The following is a description of a gene set: studied in species Homo sapiens The chemical reactions and pathways resulting in the breakdown of compounds derived from amino acids, organic acids containing one or more amino substituents. Human Gene Set: GOBP_MODIFIED_AMINO_ACID_CATABOLIC_PROCESS, and this is the list of marker genes: AGXT2, PCYOX1L, HOGA1, ALDH1L1, GOT2, PRODH, GGT7, GGT3P, DMGDH, ABHD12B, ABHD16B, DIO1, BHMT, GGTLC1, AASDHPPT, ABHD12, PCYOX1, DIO3 (NCBI Gene Id 1735), PM20D2, SARDH, ABHD16A, CHAC1 (NCBI Gene Id 79094), GGACT, ALDH1L2, CHAC2, GGTLC3, GGT1, ACADL, MTHFS, DIO2, GGT2P, GGT5, ALDH4A1, GGTLC2, DPEP1